The following is a description of a gene set: Reactome Pathway: Lanosterol biosynthesis studied in species Mus musculus electronically inferred by orthology from the curated human pathway This event has been computationally inferred from an event that has been demonstrated in another species.<p>The inference is based on the homology mapping from PANTHER. Briefly, reactions for which all involved PhysicalEntities (in input, output and catalyst) have a mapped orthologue/paralogue (for complexes at least 75% of components must have a mapping) are inferred to the other species. part of: Cholesterol biosynthesis, and this is the list of marker genes: Plpp6, Idi1, Sqle, Fdft1, Hmgcs1, Idi2